The following is a description of a gene set: Mouse Gene Set: LET_7B_5P_LET_7K species: Mus musculus from publication Chen Y, Wang X (PMID 31504780) Genes predicted to be targets of miRBase v22 microRNA mmu_let_7b_5p, mmu_let_7k in miRDB v6.0 with MirTarget v4 prediction scores > 80 (high confidence targets)., and this is the list of marker genes: Plpp6, Prpf38b, Gng5, Edn1, P2rx1, Ccr7, Ap1s1, Nipal4, Ints6l, Lin28a, Gramd2b, Trhde, Pbx3, Cercam, Lipt2 (NCBI Gene Id 67164), Lpgat1, Wnt9a, Usp38, Greb1l, Atp2a2, Fam174a, Ccnd2, Igf2bp1, Arpp19, Lin28b, Col4a2, Macf1, Ddx19a, Fnip2, Pla2g3, Rdx, Stard13, Slc2a12, Trim71, Lrig2, Fndc3b, Slc35d2, Sestd1, Arl5a, Klf8, Bach1, Ppp1r16b, Eea1, Plekha8, Brwd1, Wnt9b, Ahctf1, Fnip1, Ppp2r2a, Nap1l1, Gnptab, Gga3, Pacs2, Skil, Thoc1, Wasl, Efhd2, Hip1, Utrn, Dna2, Rbfox2 (NCBI Gene Id 93686), Soat2, Wdfy3, Osmr, Trim6, Ppargc1b, Kif21b, Nynrin, Homer2 (homer scaffolding protein 2), Thrsp, Tmem198b, Zbtb5, Tgds, Plxnd1, Tmem65, Pogz, Pxdn, 2310022A10Rik, Map3k1, G6pc2, Mapk6, Slc10a7, Gcat, Arid3a, Il6, Mycbp, Zfp275, Rab8b, Apbb3, Rgs6, Adamts8, Senp2 (NCBI Gene Id 75826), Atl2, E2f5, Hectd2, Intu, Cnot6l, Rspo2, Stx3, Snx30, Fgf11, Pbx2, Cbx5, Hmga2, Nol4l, Ngf, Ehhadh, Prtg, Xkr8, Leprotl1, Usp47, Limd2, Cflar (NCBI Gene Id 98571), 5031439G07Rik, Onecut3, Col27a1, Mapk8, Col1a2, Hdlbp, Slc16a14, Agap1, Tspan5, Kctd21, Fndc3a (fibronectin type III domain containing 3A), Crb2, Fbxl12, Slc20a1, Fign, Nras, Slc6a1, Igf1r, Rufy3, Scyl3 (SCY1-like 3 (S. cerevisiae)), Slc22a23, Gpatch3, Klk10 (NCBI Gene Id 69540), Kdm3a, Eef2k, Galnt1, Peg10, Trabd, Adamts15, Bsn, Taf9b, Dlc1, Snn, Dmd, Tmc7, Fgd6, Limk2, Casp3, Trim67, Arid3c, Slf2, Cep135 (centrosomal protein 135), Mdm4, Entrep2, Pik3ip1, B3gnt7, Arhgap12, Slc25a24, Adrb3, Stimate, Igdcc3, Sigmar1, Plekho1, Zfyve26, Rbms2, 9930012K11Rik, Nek3, Cgnl1, Tmco1, Zfp512b, Ddx19b, Dnase1l2, Dcaf15, Dtx4, Ltn1, Dnajc1, Diaph2, Gxylt1, Kif2b, Plpp5, Hand1, Hic2, Elp1 (elongator complex protein 1), Gpr156, Pcgf3, Igf2bp3, Acvr1c, Dpp3, Pde12, Arhgef15, D630045J12Rik, Rfx6, Ybey, Begain, Tmprss11f, Ndst2, Tyk2, Smim3, Ercc6, Myorg, Slc25a27, Zfp975, Lgr4, Rgs16, Pald1, Pcdh19, Smug1, Txlng, Katnbl1, Plekhg6 (pleckstrin homology domain containing, family G (with RhoGef domain) member 6), Stx17, Tmod2, Sowaha, Ttll4, P4ha2, Trim41, Rasgrp1, Scn11a, Clasp2, Mycn, Sec16b, Cep120, Sall4, Nphp3, Pappa, Etnk2, Gabra6, Cldn12, Psd3, Zfp583, Asap1, Adrb2, Fras1, Tbkbp1, Gas7, Map4k3, Acat1 (NCBI Gene Id 235373), Dusp1, Usp24, Dtx2, Thoc2, Mdfi, Vstm5, Tmprss2, Frmd4b, Lbr, Smarcad1, Zc3hav1l, Fam135a, Bcat1, Mxd1, Ddi2, E2f6, Rbpj, Ccdc71l (NCBI Gene Id 72123), Rictor, Tgfbr1, Grid2ip, Zbtb39, Pbx1, Col4a1, Nme6, Plxnc1, Ccnj, Ints2, Has2, Styk1 (NCBI Gene Id 243659), Gdf6, Cntrl, Cpeb1, Gatm, Prrx1, Col5a2, Tnfaip8l3, Abcb9, Faxc, Gpatch2, Zswim5, Cemip2, Liph, 1700017B05Rik, Stxbp5, Egln2, Dnaja2, Cpa4, Cbx2, Zmat4, Galnt2, Cry2, Hif1an (hypoxia-inducible factor 1, alpha subunit inhibitor), Igf2bp2, Col3a1, Adamts12, Pcdh20, Coil, Kctd17, Nemp1, Prkaa2, Pard6b, Stk40, Zfp282, Tgfbr3, Onecut2, Slc66a1 (NCBI Gene Id 212555), Cd200r1, Slc38a9, Map4k4, Brd3, Ptafr, Syt11, Mfsd4a, Alg11, Igdcc4, Arhgap28, Rab11fip4, Slc7a14, Pitpnm3, Dusp22, Fignl2, Arid3b, Lrig3 (NCBI Gene Id 78922), Klhl6, Cpeb2, E2f2, Hook1, Bzw1, Nr6a1, Cdc34, Tet3, Fasl, Il13, Hoxa1, Yod1, Sall3, Gpcpd1, Masp1, Alox8, Map3k2